Given this list of marker genes HNRNPU, L3MBTL3 (NCBI Gene Id 84456), BAZ1A, DNMT3L, CDK2, TLK2, MKI67, MBD3L2, LSM11 (LSM11, U7 small nuclear RNA associated), TLK1, TAL1, SAMD1, PHF2, JPX, PAX7, KMT2A, MACROH2A1, DYRK1A, KDM1A, RLF, SSRP1, MLLT3, TPR, PHF8, SETD1A, SETD5, here is a description of the gene set: Human Gene Set: GOBP_REGULATION_OF_CHROMATIN_ORGANIZATION Any process that modulates the frequency, rate or extent of chromatin organization. species: Homo sapiens